Given this list of marker genes Cldn16, Cldn3, Cadm1, Cldn15 (claudin 15), Cldn10, Cldn11, Cldn19, Cldn18, Cldn9, Dscaml1, Cldn4, Cx3cl1 (NCBI Gene Id 58173), Cldn7, Cldn8, Cldn5, Cldn17, Cldn1, Cldn12, Cldn6, Cldn2, Cldn23, Bmp2, Cldn22, Esam, Cldn14, here is a description of the gene set: studied in species Mus musculus Mouse Gene Set: GOBP_CALCIUM_INDEPENDENT_CELL_CELL_ADHESION_VIA_PLASMA_MEMBRANE_CELL_ADHESION_MOLECULES The attachment of one cell to another cell via adhesion molecules that do not require the presence of calcium for the interaction.